The following is a description of a gene set: studied in species Mus musculus Mouse Gene Set: GOBP_MITOTIC_NUCLEAR_MEMBRANE_ORGANIZATION A mitotic cell cycle process which results in the assembly, arrangement, or disassembly of the nuclear inner or outer membrane during mitosis., and this is the list of marker genes: Reep4, Banf1, Ankle2, Reep3, Brox